Given this list of marker genes Glg1, Zfp825, Septin11, Ubn1, Smad9 (NCBI Gene Id 55994), Nptn, Rab2b, Csf2, Tnrc6b, Cstf2, Gpc6, Large1, Ccnj, Serpinb2, Bcl2l1, Amph, Rabgap1, Rbfox1, Mfsd6, Ccdc30, Plekha7, Memo1, Dynlt3, Crbn, Akr1c18, Zfp42, Gcfc2, Rgl2, Prom1, Ano2, here is a description of the gene set: studied in species Mus musculus from publication Chen Y, Wang X (PMID 31504780) Mouse Gene Set: MIR_219A_1_3P Genes predicted to be targets of miRBase v22 microRNA mmu_miR_219a_1_3p in miRDB v6.0 with MirTarget v4 prediction scores > 80 (high confidence targets).